Given this list of marker genes DNA2, DOK1, PAX8, CHD9, PRELID3A, GRIK5, GRIP2, SLC24A1, AGPS, CHD3, SLC30A3, MT4, FDXR, SLC30A1, RANBP2, KLHL18, MTX1, MC2R, KRT33A, GALNT2 (polypeptide N-acetylgalactosaminyltransferase 2), PPP5C, KIAA0586, ERAL1, EML3, MPP2, ATRX, OARD1, TAF2, FANCG, CDK13, COLQ, GPATCH8, LSM12, BTD, B4GALT3, DIMT1, AMFR, ITIH4, TMEM11, BAHD1, BPHL (biphenyl hydrolase like), EIF5B, CPSF4, SIK3, PIGB (NCBI Gene Id 9488), PCGF1, ERCC2, INPP5E, TMEM94, NFYB, MUTYH, EXTL3, SSTR5, WDR62, HNRNPL, FRYL, HTR7, ZNF592, RBBP8, CLP1, LSM1, NCKIPSD, MFN2, ZNF500, NFRKB, PPIL2, DDX11, AP3B1, CSTF3, EIF4E, DNAJC7, LDB1, HTR4, KANK2, SPEF1, IRF2BP1, ENTREP1, TTI1, CSNK2A1, JRK, SH2B1, IMPA1, CLPX, here is a description of the gene set: Neighborhood of HEAB studied in species Homo sapiens Neighborhood of HEAB - in the MORF expression compendium Human Gene Set: MORF_HEAB